The following is a description of a gene set: Genes co-regulated in uterus during a time course response to progesterone: SOM cluster 14. from publication Yao MW, Lim H, Schust DJ, Choe SE, Farago A, Ding Y, Michaud S, Church GM, Maas RL (PMID 12554760) Human infertility and recurrent pregnancy loss caused by implantation defects are poorly understood. Hoxa-10-deficient female mice have severe infertility and recurrent pregnancy loss due to defective uterine implantation. Gene expression profiling experiments reveal that Hoxa-10 is an important regulator of two critical events in implantation: stromal cell proliferation and local immunosuppression. At the time of implantation, Hoxa-10 mediates the progesterone-stimulated proliferation of uterine stromal cells. Hoxa-10 mutants express a stromal cell proliferation defect that is accompanied by quantitative or spatial alterations in the expression of two cyclin-dependent kinase inhibitor genes, p57 and p15. Hoxa-10 deficiency also leads to a severe local immunological disturbance, characterized by a polyclonal proliferation of T cells, that occurs in place of the normal progesterone-mediated immunosuppression in the periimplantation uterus. Mouse Gene Set: YAO_TEMPORAL_RESPONSE_TO_PROGESTERONE_CLUSTER_14 studied in species Mus musculus, and this is the list of marker genes: Tmem14c, Fbl, Acod1, Pkdcc, Eif4g1, Ergic1, 1810009A15Rik, Calca, Slain1, Rgs19, Mrps10, Tmem97, Slc39a7, Tubb6, Ptp4a3, Sec61a1, Tyms, Rars1, Htra2, Tmem167, Banf1, Cisd1, Arxes2, Ipo5, Rwdd1, Nop16, Arhgdia, Syncrip, Tuba1a, Mme, Dnajc2, Gorasp2 (NCBI Gene Id 99405), Ipo4, Gstm2, Fgf1, Carm1, Psmb5, Uqcc2, Fkbp11, Prelid3b, Vcl, Pth1r, Hmgn5 (high-mobility group nucleosome binding domain 5), Ybx3, P3h4, Prmt1 (protein arginine N-methyltransferase 1), Gga1 (golgi associated, gamma adaptin ear containing, ARF binding protein 1), Gps1, Nhp2, Tbcb, Cdk2ap1, Padi2, Bbln, Tmem147, Srsf1, Ube2n-ps1, Snd1, Atf6b, Serpine2, Clptm1l, Metap1, Pabpc4, Nubp1, Mrps18b, Pkm, Pdia4, Eif2b5, Pigq, Psme4, Ssr1, Ebna1bp2, Col18a1, Tcerg1, Psmd6, Vars1, Pdia3, Irak1, Dvl3, Dctpp1, Ssr2, Prep, Galm, Nars1, Jag2, Nme1, Ran, Ptov1, Smarca4, Odc1, Tcea1, Gnpnat1 (glucosamine-phosphate N-acetyltransferase 1), Rpn1, Snrpd3, Cct3, Psmd1, Morf4l2, Tpd52, Sec61b, Apex1, Ube2m, Ranbp1, Wdr74, Lman2, Prrc1, Ssr3, Thop1, Gatad2a, Asl, Sec13, Mydgf, Rcn1, Hdlbp, Hnrnpa3 (NCBI Gene Id 69921), Ddx41, Golga5, Pes1, Acta1, Cct8, Tubb3, Tomm70a, Pdlim3, Psmb3, Dtymk, Mrpl20, Cdk4, Ppp1r14b, Bax, 2310061I04Rik, Nsun2, Smyd2, Eftud2, Ubfd1, Nde1 (NCBI Gene Id 67203), Cs, Serpinh1, Rab34, Ctsd, Ykt6, Galk1, Mrpl12, Mlec, Ppa1, Tank, Snrpa1